The following is a description of a gene set: Genes upregulated in subsets of cells of a given type within various tumors studied in species Homo sapiens In this study, an extensive analysis was conducted to define meta-programs (MPs) capturing intra-tumor heterogeneity across a spectrum of tumor types. The approach utilized non-negative matrix factorization (NMF) to analyze each cell type separately within individual tumor samples. This involved the analysis of malignant cells, macrophages, fibroblasts, endothelial cells, epithelial cells, T-cells, and B-cells. NMF was executed with varying parameter values (K=4, 5, 6, 7, 8, 9), thereby generating 39 programs for each cell type per sample. Each NMF program was summarized by the top genes based on NMF coefficients.\nRobust MPs were then delineated for each cell type using a set of stringent criteria, including recurrence within the same tumor, similarity to programs in other tumors, and non-redundancy within a tumor. Subsequently, these robust NMF programs were clustered (per cell type) based on Jaccard similarity, leading to the identification of MPs associated with each cell type.\nTo enhance the quality of the MPs, a refinement steps were undertaken, involving the removal of MPs suspected of reflecting low-quality data (with an overrepresentation of ribosomal proteins or mitochondrial-encoded genes), single-study inclusion, or similarity to miss-annotated cell types. from publication Gavish A, Tyler M, Greenwald AC, Hoefflin R, Simkin D, Tschernichovsky R, Galili Darnell N, Somech E, Barbolin C, Antman T, Kovarsky D, Barrett T, Gonzalez Castro LN, Halder D, Chanoch-Myers R, Laffy J, Mints M, Wider A, Tal R, Spitzer A, Hara T, Raitses-Gurevich M, Stossel C, Golan T, Tirosh A, Suvà ML, Puram SV, Tirosh I (PMID 37258682) Human Gene Set: GAVISH_3CA_MALIGNANT_METAPROGRAM_32_SKIN_PIGMENTATION, and this is the list of marker genes: APOE, SNX10, SNCA, GJB1, SH3BP5, MXI1, CHCHD6, NSG1, SLC45A2, TNFRSF14, ISG20, TRIM2 (tripartite motif containing 2), NBL1 (NCBI Gene Id 4681), PHACTR1, GDF15, BIRC7, LGALS3, GYPC, AVPI1, CCN3, MLANA, WIPI1, ZNF106, PLP1, FXYD3, TYRP1, LINC00518, LYST, TRPM1, SPON2, CAPN3, RAB38, TBC1D7, MITF, MBP, GPNMB, PIR, RRAGD, GPR143, DAB2, ASAH1, QPCT, PMEL, BCL2A1, TBC1D16, QDPR, TIMP2, S100B, GPR137B, DCT